Given this list of marker genes Cyb5r4, Ndor1 (NADPH dependent diflavin oxidoreductase 1), Por, Cyp2j6, Mtrr, here is a description of the gene set: Mouse Gene Set: GOMF_NADPH_HEMOPROTEIN_REDUCTASE_ACTIVITY species: Mus musculus Catalysis of the reaction: NADPH + H+ + n oxidized hemoprotein = NADP+ + n reduced hemoprotein.